The following is a description of a gene set: part of: Assembly of collagen fibrils and other multimeric structures species: Mus musculus Reactome Pathway: Anchoring fibril formation This event has been computationally inferred from an event that has been demonstrated in another species.<p>The inference is based on the homology mapping from PANTHER. Briefly, reactions for which all involved PhysicalEntities (in input, output and catalyst) have a mapped orthologue/paralogue (for complexes at least 75% of components must have a mapping) are inferred to the other species. electronically inferred by orthology from the curated human pathway, and this is the list of marker genes: Bmp1, Col7a1, Tll2